The following is a description of a gene set: Mouse Gene Set: MIR_154_5P Genes predicted to be targets of miRBase v22 microRNA mmu_miR_154_5p in miRDB v6.0 with MirTarget v4 prediction scores > 80 (high confidence targets). from publication Chen Y, Wang X (PMID 31504780) species: Mus musculus, and this is the list of marker genes: Ube2h, Slc2a12, Ttr, Parg, Tars3, Megf11, Dll3, Acot2, Glb1l3, Zeb2, E2f5, Slc38a2, Tceanc, Nudt4, Asap2, Stam (signal transducing adaptor molecule (SH3 domain and ITAM motif) 1), Erc2, Cdh20, Pcna, Plek, Aqp9, Elovl7, Pnoc, Hivep2, Cdca4, Adamtsl3, Nkain2, Cadm2, Psmd9, Tet3, Cstf3, Hectd4, Pask, Capn6, Dock1 (dedicator of cytokinesis 1), Eps15, Ptk6, Cibar1, Fermt2, Hdhd2, Plppr1, Slc16a9, Manea, Mindy2, Kctd14, Evi5, Optc, Or52n4, Tmem108, Hnrnpr, Vmn1r32, Cul2 (NCBI Gene Id 75720), Serpinb2, Klf6, Eri1